The following is a description of a gene set: The series of molecular signals initiated by a ligand binding to a glial cell-derived neurotrophic factor receptor. Human Gene Set: GOBP_GLIAL_CELL_DERIVED_NEUROTROPHIC_FACTOR_RECEPTOR_SIGNALING_PATHWAY studied in species Homo sapiens, and this is the list of marker genes: MMP14, GFRA1, GDNF, GFRA2, SULF2 (NCBI Gene Id 55959), GATA3 (NCBI Gene Id 84828), GFRA3, NRTN, ARTN, PSPN, GFRA4, RET, GFRAL, SULF1, GDF15